The following is a description of a gene set: Mouse Gene Set: GOBP_INTRACELLULAR_PROTEIN_TRANSMEMBRANE_TRANSPORT The directed movement of proteins in a cell, from one side of a membrane to another by means of some agent such as a transporter or pore. studied in species Mus musculus, and this is the list of marker genes: Pex14, Trim37, Tram1l1, C2cd5, Rtn2, Sec63, Pex16, Pex7, Lonp2, Srp54c, Tram2, Pex26, Usp9x, Sec61g, Pex12, Glp1r, Pex10, Pex2 (NCBI Gene Id 52109), Sec61a1, Hspa5, Pex5l, Zfand2b, Sec61a2, Pex1, Bcr (NCBI Gene Id 71258), Pex6, Pex13, Pex5, Sec62, Sec61b, Srp54a (NCBI Gene Id 24067), Tram1